The following is a description of a gene set: The directed movement of a protein to a specific location in the telomeric region of a chromosome. studied in species Mus musculus Mouse Gene Set: GOBP_ESTABLISHMENT_OF_PROTEIN_LOCALIZATION_TO_TELOMERE, and this is the list of marker genes: Nabp2, Spdya, Cct6a, Acd, Pot1b, Dkc1, Cct3, Cct4, Cct8, Zfp827 (NCBI Gene Id 78397), Terf1, Wrap53, Tert, Brca2, Cct7, Cct5, Tcp1, Pot1a, Cct2